Given this list of marker genes POLR2L, POLR2I, POLR2B, POLR2J, GTF2F2 (NCBI Gene Id 2963), POLR2F, GTF2F1, NCBP1, POLR2A, POLR2D, POLR2K, POLR2C, FGF2, FGF1, FGFR2, NCBP2, POLR2G, POLR2H, POLR2E, here is a description of the gene set: studied in species Homo sapiens Human Gene Set: REACTOME_SIGNALING_BY_FGFR2_IIIA_TM Signaling by FGFR2 IIIa TM